The following is a description of a gene set: Human Gene Set: KEGG_MEDICUS_VARIANT_MUTATION_INACTIVATED_PRKN_TO_INTRINSIC_APOPTOTIC_PATHWAY Mutation-inactivated PRKN to intrinsic apoptotic pathway. Pathway ID: N01049. Pathway type: Variant. Pathway class: nt06463 Parkinson disease. studied in species Homo sapiens Pathway Definition from KEGG: PRKN* // BAX -> CYCS == APAF1 -> CASP9 -> CASP3, and this is the list of marker genes: CYCS, CASP9, BAX, PRKN, CASP3, APAF1